Given this list of marker genes RNF31, TYMP, BRCA1, POLG, BRCA2, UBE3C, PALB2, ACSF3 (acyl-CoA synthetase family member 3), GATA6, ATP6V0A1, PALLD, TP53, RABL3, CDKN2A, TLK2, G6PC1, DOCK2, KRAS, ZNFX1, COG4, SMAD4, ATRX, here is a description of the gene set: Intermittent diarrhea Human Gene Set: HP_INTERMITTENT_DIARRHEA Repeated episodes of diarrhea separated by periods without diarrhea. species: Homo sapiens